Given this list of marker genes Psmb4, Cdk4, Adrm1, Psmb1, Orc3, Uba52, Prim2, Psma6, Skp1, Orc6, Ubb, Rpa3, Lin54, Psmb6, Psmc6, Cdkn1a, Tfdp1, Ccnh, Psmd1, Psmd8, Psmc3, Psma2 (proteasome subunit alpha 2), Psmc5, Cdkn1b, Cables1, Psmd6, Cdk7, Ppp2r2a, Ccnd2, Pola1, Psmd11, Psmb3, Ppp2r3d, Mcm3, Cdt1, Rbl2, Cks1b, Psmd12, Cul1, Abl1, Ccnd3, Rb1, Ptk6, Rpa2, Akt1, E2f2, Mcm6, Psma4, Pole3, Mcm10, Psma5, Orc5, Akt3, Pole4, Ubc, Dbf4 (DBF4 zinc finger), Mnat1, Psmb7, Rbbp4, Mcm7, Mcm2, Orc4, E2f3, Ccne1, Pole2 (NCBI Gene Id 18974), Ppp2r1a, Psmd2, Cdc45, Cdkn2b, Mcm4, Psmb5, Psmb2, Psmc2, Dyrk1a, Psma7, Psma3, Rbl1, Psmd3, Lyn (NCBI Gene Id 99963), Cdc25a, E2f5, Psmc1, Cdc7, Mcm5, Lin37, Lin9 (lin-9 DREAM MuvB core complex component), Jak2, E2f1, Ppp2cb, Skp2, Lin52 (lin-52 DREAM MuvB core complex component), Uba52rt, Ccne2, E2f4, Mcm8, Rps27a, Ccna1, Hdac1, Psmd7, Prim1, Akt2, Rpa1, Psmd14, Psmd13, Wee1, Psma1, Pola2, Ppp2ca, Gmnn, Orc1, Ccnd1, Orc2, Psmc4, Ccna2, Cdk2, Src, Cdc6, Pole, Ppp2r1b, Cdk6 (cyclin dependent kinase 6), Cdkn1c, here is a description of the gene set: species: Mus musculus Mouse Gene Set: REACTOME_MITOTIC_G1_PHASE_AND_G1_S_TRANSITION Mitotic G1 phase and G1/S transition